The following is a description of a gene set: studied in species Homo sapiens Optic neuropathy Human Gene Set: HP_OPTIC_NEUROPATHY, and this is the list of marker genes: CISD2, NDUFB9, NDUFS2, NDUFS7, NDUFV2, NDUFAF2, MT-ATP6, LDLR, ATN1, NDUFAF3 (NADH:ubiquinone oxidoreductase complex assembly factor 3), EFEMP1, TSFM, MT-ND2, NDUFB11, MT-CO3, NDUFAF4, NDUFA6, NDUFB3, AGXT, NDUFS4, MTRFR, GP1BA, FOXRED1, MT-CYB, PCSK9, NDUFAF8, NDUFS3, CLCN2, MT-ND5 (mitochondrially encoded NADH:ubiquinone oxidoreductase core subunit 5), MT-ND4L, NDUFA11, MYOC, APOB, NDUFS1, NDUFA13, TIMMDC1, NDUFS8, TMEM53, NDUFS6, NDUFA1, BTD, MT-ND4, GSN, NDUFAF5, MT-ND1 (NCBI Gene Id 4535), SPTAN1, ABCG8, NDUFB10, TMEM126B, NUBPL, NOTCH3, NDUFV1, HLA-DRB1, WDR11, CYP1B1, LDLRAP1, ABCG5, MT-ND3, NDUFAF1, SH3BP2, CYP27A1, MT-ND6, TXN2